Given this list of marker genes Kras, Pten, Tgfbr2, Ctnnb1, Msmb, Cop1, Acp3, Apc, here is a description of the gene set: studied in species Mus musculus Mouse genes annotated to increased prostate gland adenocarcinoma incidence (MP:0009220) retrieved from the Mouse Genome Informatics database via MouseMine Mouse Gene Set: MP_INCREASED_PROSTATE_GLAND_ADENOCARCINOMA_INCIDENCE from publication Motenko H, Neuhauser SB, O'Keefe M, Richardson JE (PMID 26092688)